Given this list of marker genes GLYCTK, PFKFB3, PFKFB1, KHK, SORD, FBP1, AKR1B1, ALDOB, ALDOA, FBP2, TKFC, PFKFB4, PFKFB2, ALDOC, here is a description of the gene set: species: Homo sapiens Human Gene Set: GOBP_FRUCTOSE_METABOLIC_PROCESS The chemical reactions and pathways involving fructose, the ketohexose arabino-2-hexulose. Fructose exists in a open chain form or as a ring compound. D-fructose is the sweetest of the sugars and is found free in a large number of fruits and honey.